The following is a description of a gene set: Genes that physically map to the hematopoietic stem cell (HSC) proliferation QTL (quantitative trait locus) Scp2. studied in species Mus musculus We combined large-scale mRNA expression analysis and gene mapping to identify genes and loci that control hematopoietic stem cell (HSC) function. We measured mRNA expression levels in purified HSCs isolated from a panel of densely genotyped recombinant inbred mouse strains. We mapped quantitative trait loci (QTLs) associated with variation in expression of thousands of transcripts. By comparing the physical transcript position with the location of the controlling QTL, we identified polymorphic cis-acting stem cell genes. We also identified multiple trans-acting control loci that modify expression of large numbers of genes. These groups of coregulated transcripts identify pathways that specify variation in stem cells. We illustrate this concept with the identification of candidate genes involved with HSC turnover. We compared expression QTLs in HSCs and brain from the same mice and identified both shared and tissue-specific QTLs. Our data are accessible through WebQTL, a web-based interface that allows custom genetic linkage analysis and identification of coregulated transcripts. from publication Bystrykh L, Weersing E, Dontje B, Sutton S, Pletcher MT, Wiltshire T, Su AI, Vellenga E, Wang J, Manly KF, Lu L, Chesler EJ, Alberts R, Jansen RC, Williams RW, Cooke MP, de Haan G (PMID 15711547) Human Gene Set: BYSTRYKH_SCP2_QTL, and this is the list of marker genes: CCL15, GGNBP2, PSMB6, MPO, LIG3, KIF1C